The following is a description of a gene set: Serial comparison between Th1 and Th17 tumor-specific cells cultured in vitro and ex vivo after transferred into sublethaly irradiated B6.PL mice. Th17-derived cells acquire Th1-like properties in vivo but maintain a distinct molecular profile. Human Gene Set: GSE26030_UNSTIM_VS_RESTIM_TH1_DAY15_POST_POLARIZATION_DN from publication Muranski P, Borman ZA, Kerkar SP, Klebanoff CA, Ji Y, Sanchez-Perez L, Sukumar M, Reger RN, Yu Z, Kern SJ, Roychoudhuri R, Ferreyra GA, Shen W, Durum SK, Feigenbaum L, Palmer DC, Antony PA, Chan CC, Laurence A, Danner RL, Gattinoni L, Restifo NP (PMID 22177921) species: Homo sapiens Genes down-regulated in Th1 cells 15 days post polarization: control versus stimulated with anti-CD3 and anti-CD28., and this is the list of marker genes: SKA2, CCND1 (NCBI Gene Id 893), CYB561, PTK2B, JPT1, HFE, MGAT4B, SP4, MAN2C1, TKT, CD83, PFN1, RPS6KA2, NFKBIZ, NMT1, IGLC7, RHOQ, SH2D1B, ADGRE1, IRF3, S1PR4, BCL2A1, ITGB3, SMC6, FCER1G, TTC7B, CLDN15, CYRIA, PAG1, EMD, NCAPD2, FCRL1, CNST, HIC2, CTSB, SGMS1, CITED4, QSOX2, LIMD2 (LIM domain containing 2), PIP4K2A, SSTR4, SIPA1L1, ORC6, SCP2, VAMP5, UCP2 (NCBI Gene Id 7351), ANGPTL4, SLC11A1, TRIB1 (tribbles pseudokinase 1), ACAT2, EXOSC2, LY75, RASGRP1, ABI3, JMJD6, ITGAL, GSK3A, C2orf69, PLEK, CENPT, PDK1, FCGR3A, FGFRL1, RAB19, NADK, LOXL3, KCNK5, E2F4, ZNF608, SH3D19, STK10, TGM3, SLC39A13, MXI1, TUBB6, ARHGEF10L, ZFAND5, GPR137B, DEF6, B4GALT5, TRAF1, TCEA3, DDIT3, HCK, THAP4, BTBD19, FILIP1L, PHLPP1, BRD9, C5AR1, NUP35, RHOF, DENND6B, PPM1B, LIMA1, SYCE2, SLC29A1, MYO1G, INPP1, CARM1, CDK2AP1, PTPN12, ST3GAL5, SF1, TUBB4B, CSF1R, CHADL, HAUS1, RHOA, MAPRE2, POU2F2, PBXIP1, AAAS, SAFB2, HAUS5, ALDH18A1, NUAK2, PLEKHA6, NFATC3, DNAJC9, ACSS1, KRAS, ADGRL2, ABCC5 (ATP binding cassette subfamily C member 5), BSPRY, CYB5A, NR1D1, CLUH, MTBP, CDKN2AIPNL, SORT1, FAM98C, CEPT1, DDIT4, CYFIP2, CDH1, CBLB, TFDP2, ABHD3, SVIL, NR1H3, STK38, ADAMDEC1, PIP4K2C, BCDIN3D, GPR35, CELF1 (NCBI Gene Id 10658), UNC119, NUP210, C11orf54, UBE2S, SERPINB6, C14orf28, NFKBIA, ATMIN, CCM2 (NCBI Gene Id 9225), TTI1, YWHAZ, SLC44A2, EXTL3, RRM1, CD300A, C3orf33, ETS1, C17orf58, B4GALNT1, STAP1, RGS3, SPATA13, DNAH12, CPT1A, SQSTM1, ACTN4, PHF1, RIMS3, STK24, BUB1B, ZNF507, SCRIB, CCDC97, TAMALIN, AFDN, TGFBR1, ESYT3, SMAGP, PIGL, AK2, APOBR, TEF, MTF1, ANKRD33B, CENPQ, FAM135A, BUB3, MSN, FZD2, TPCN2, STK4, ALDH9A1, RAP1GAP2